The following is a description of a gene set: species: Homo sapiens Human Gene Set: HP_SCLERAL_STAPHYLOMA Scleral staphyloma A staphyloma is a localized defect in the eye wall with protrusion of uveal tissue due to alterations in scleral thickness and structure., and this is the list of marker genes: PIGT, VPS4A, PAX2, CFAP410, HADHA, BEST1, OCA2, ARL2, MC1R, IMPG2